The following is a description of a gene set: Pathway Definition from KEGG: FASLG -> FAS -> FADD -> (RIPK1+RIPK3) species: Homo sapiens FASLG-RIPK1/3 signaling pathway. Pathway ID: N01632. Pathway type: Reference. Pathway class: nt06527 Necroptosis. Human Gene Set: KEGG_MEDICUS_REFERENCE_FASLG_RIPK1_3_SIGNALING_PATHWAY, and this is the list of marker genes: FADD, RIPK3, RIPK1, FAS, FASLG